Given this list of marker genes Fam170b, Eqtn, Sun1, Glipr1l1, Tekt3 (tektin 3), Spaca4, Trip11, Zp3r, Tmem225, Ift88, here is a description of the gene set: The acrosomal membrane region that underlies the plasma membrane of the sperm. This membrane fuses with the sperm plasma membrane as part of the acrosome reaction. Mouse Gene Set: GOCC_OUTER_ACROSOMAL_MEMBRANE species: Mus musculus